Given this list of marker genes SPC24, ATP4B, CERS6, TUBE1, UMPS, NUAK1, RBM44, SRPK3 (NCBI Gene Id 26576), PLXND1, CHADL, PAX5, GEN1, PRR11, SEPTIN6, GAS2, RPP40, ZNF428, NMT1, MYBL2, DCK, OXNAD1, ASXL2, FANCD2, UHRF1, YARS1, CLGN, APOLD1, LRR1, HAUS6, FIRRM, TMPRSS3, ANG, TOX4, GINS1, ATF7, RAD51C, CBX1, SLC27A2, HIVEP3, TMEM69, SLC43A3, SLC7A5, STRBP, GAMT, MASTL, QPCT, CD5, EME1, TRAPPC1, AUNIP, PRSS23, ADM, ARID1B, CTPS1, POLR3K, CD48, PPP2R5E, SACS, ADA, PLXDC1, AGFG1, HADHB, CPSF2, KRAS, DDIAS, LY9, URB2, H2AX, CENPF, KIF18A, CCP110, NLRC3, DLEU7, EPS8L3, RNASE4 (NCBI Gene Id 6038), HAND2, TRAPPC2, CCNE2, ZBTB8OS, ARAP2, SPATA24, MYL4, SRP19, FAM174C, FGF14, RSPH9, RNASEH2B, ENDOD1, INTS11, THOP1 (NCBI Gene Id 92731), EIPR1, SCFD2, RECQL4, TMEM119, NOLC1, SUMF1, RBIS, TRAF2, TTPAL, POP4, TMEM243, TXNRD3, TMEM26, CHCHD10, TENT4A, RBM6, SGO1, SMYD5, DGCR8, BYSL, WDR4, SAP30, FOXO1, MLX, HYOU1, CYB561A3, CIP2A, VMA21, DLGAP5 (NCBI Gene Id 9787), CIMIP1, GOLGA3, ERCC6L, CEP128, BRMS1, SNRPD1, CDCA5, NASP, SGK1, MIS18BP1, CMSS1, SBK1, KIFC1, DDX41, LRRC40, COLQ, GPATCH8, BMAL1, TRIM2, TACC3, ARHGAP19, KIF23, BRCA1, TOMM70, MYO19, CDCA3, E2F7, SAP30BP, CPLX2, LY6D (lymphocyte antigen 6 family member D), PIK3R6, MDC1, LSM5, LY86, DNAJC15, CEP55 (NCBI Gene Id 94765), TNFRSF19, TTC16, MTAP, LAMC1, METTL6, RNF7, XIST, ERI2, FAM72A, MTRES1, CYTH1, PHF5A, ARL6IP6, NRARP, DGKE, TBL3 (transducin beta like 3), MYEF2, ITGAL, CCDC124, NMNAT2, UBE2L3, GTF2F2, PDCD1, UBD, FCRLA, CENPP, GPD1L, RAPGEF5, MZB1, ATP6V0E2, CIT, DNTT (NCBI Gene Id 1791), TIFAB, PREP, SLC1A7, SAPCD1, LONRF2, INCENP, CTCF, LGR5, MMP11, STAG1, CENPQ, BRMS1L, CKAP2L, here is a description of the gene set: The process for making monocyte derived DCs (moDCs) has been previously described (46). All analysis was performed on “day 5” immature DCs. Etanercept 10mg/mL was added to experimental wells on days 0, 2, and 4. We chose this concentration of etanercept as it approximates the plasma concentration of drug when given 50mg BIW. Genes down-regulated in monocyte-derived dendritic cells: control versus TNF inhibitor etanercept. Human Gene Set: GSE9239_CTRL_VS_TNF_INHIBITOR_TREATED_DC_DN from publication Zaba LC, Cardinale I, Gilleaudeau P, Sullivan-Whalen M, Suárez-Fariñas M, Fuentes-Duculan J, Novitskaya I, Khatcherian A, Bluth MJ, Lowes MA, Krueger JG (PMID 18039949) studied in species Homo sapiens